The following is a description of a gene set: species: Homo sapiens Human Gene Set: HP_ULNAR_DEVIATION_OF_THE_HAND_OR_OF_FINGERS_OF_THE_HAND Ulnar deviation of the hand or of fingers of the hand, and this is the list of marker genes: HOXA13, DHCR7, SLC26A2, COL9A1, ERI1, SALL1, COMP, HRAS, LIFR, TNNT3 (troponin T3, fast skeletal type), BMP2, MYH3, ALG9, ASXL3, CD96, DPYSL5, TGDS, FLNA, GDF5, HOXD13, SHOX, TBX22, RBM28, PIEZO2, MAP3K7, LAMA5, CHRNG, MUSK, LBR, COL9A2, MAFB, ADGRG6, TPM2, CRKL, CILK1, TBX5, FBN2, MAN2C1, COL9A3, FAT4 (FAT atypical cadherin 4), RAB3GAP2, PAX3, RYR3, B9D2, MYMK, RBM8A, RAB3GAP1, DACT1, TNNI2, PTRH2, NALCN (sodium leak channel, non-selective), MYMX, MAPK1, BMPR1B, WNT7A, MYBPC1, COG1, SPART, FRA10AC1, ZEB2, BICD2, MED12, BCR, PIK3CA, ANKRD11, PCDHGC4, PEX1, TRAF7